Given this list of marker genes AIFM1, INHBA, HCN2, CARD9, PARP1, CYBB, CRH, SCNN1D, SGK1, SCNN1A, PTPRC, SCNN1B, SH3RF1, SCNN1G, STK39, SLC12A3, CYBA, here is a description of the gene set: species: Homo sapiens Any process that results in a change in state or activity of a cell or an organism (in terms of movement, secretion, enzyme production, gene expression, etc.) as a result of an aldosterone stimulus. Human Gene Set: GOBP_RESPONSE_TO_ALDOSTERONE